The following is a description of a gene set: A type of arrhythmia that originates above the ventricles, whereby the electrical impulse propagates down the normal His Purkinje system similar to normal sinus rhythm. Human Gene Set: HP_SUPRAVENTRICULAR_ARRHYTHMIA Supraventricular arrhythmia species: Homo sapiens, and this is the list of marker genes: SCNN1A, TECRL, KCNE5, MT-ATP6, XK, TNNT2, MYL2, SYNE1 (NCBI Gene Id 85448), NEXN, TTN, NUP155, RYR2 (NCBI Gene Id 6262), CALM1, CACNA1C, POLG, LAMP2, MFAP5, SMAD3, CSRP3, TTR, CLIC2, NDUFB11, SPRED1, SCN5A, COX7B, GATAD1, DTNA, KCNJ5, KCNH2, KIF20A, HCCS, SCN1B, CITED2, RANGRF, TAB2, AKAP9 (A-kinase anchoring protein 9), FRG1, GATA5, LMNA, MYH6, KCNE3, SLC25A4, DBH, FHL1, PKP2, NRAS, SCN4B, TRDN, COL4A1, DES, CALM2, TNNI3, TBX20 (NCBI Gene Id 57057), EMD (NCBI Gene Id 2010), BMP2 (bone morphogenetic protein 2), LMOD2, CAP2, KCNQ1, CIZ1, SMCHD1, PLN, FLAD1, MYL4, KCNE1, NPPA, TMEM43, PRKAG2, DMPK, CDH23, KCNJ8, MYPN, SCN2B, TBX5, KCNK3, POLG2 (NCBI Gene Id 11232), TLL1, GPD1L, SLC19A2, RRM2B, SGO1, HCN4, SEMA3A, KCNA5, NODAL, KCTD1, CAPNS1, FLNC, TNNC1, PSEN2, ACTN2, TRPM4, KCNJ3, CACNA2D1, CACNB2, KCNJ2, ACTC1, RYR1, APRT, CASQ2, DNMT3B, MYOZ2, JPH2, KCNE2, MYH7, DNMT3A, ZFHX3, SCN3B, NAA10, LRP12, KCND3, NKX2-5, FBXL4, TPM1, SLC4A3, SLMAP, CORIN, GATA6, SYNE2, TWNK, NKX2-6, ANK2, GNB2, FHOD3 (NCBI Gene Id 80247), SCN10A, CACNA1S, DUX4L1, CALM3, TNNI3K, PITX2, DUX4, GJA5, CAVIN1 (NCBI Gene Id 284119), GATA4 (NCBI Gene Id 2626), ABCC9, MT-CYB